The following is a description of a gene set: Any process that modulates the rate, frequency, or extent of superoxide metabolism, the chemical reactions and pathways involving superoxide, the superoxide anion O2- (superoxide free radical), or any compound containing this species. species: Homo sapiens Human Gene Set: GOBP_REGULATION_OF_SUPEROXIDE_METABOLIC_PROCESS, and this is the list of marker genes: F2RL1, APP, PRKCD, PON3, GCH1, MAPT, CD36, ITGB2, FBLN5, ELAVL1, AGT, BST1, MIR27B (microRNA 27b), CYBA, SYK, CLEC7A, BMP7, DHFRP1, GNAI2 (G protein subunit alpha i2), TGFB1, DHFR, FPR2, PRKCE, GSTP1, CRP, TYROBP, ACP5, ITGAM, SOD1, SHC1, CD177, NFE2L2 (NCBI Gene Id 4780)